The following is a description of a gene set: species: Homo sapiens Demyelination of peripheral motor nerves. Demyelinating motor neuropathy Human Gene Set: HP_DEMYELINATING_MOTOR_NEUROPATHY, and this is the list of marker genes: TFG, GJC2, NEFL (neurofilament light chain), SELENOI, RNASEH1, SPTBN4